The following is a description of a gene set: Reactome Pathway: Synthesis of DNA part of: DNA Replication; S Phase studied in species Mus musculus This event has been computationally inferred from an event that has been demonstrated in another species.<p>The inference is based on the homology mapping from PANTHER. Briefly, reactions for which all involved PhysicalEntities (in input, output and catalyst) have a mapped orthologue/paralogue (for complexes at least 75% of components must have a mapping) are inferred to the other species. electronically inferred by orthology from the curated human pathway, and this is the list of marker genes: Anapc10, Mcm8, Psmb5, Ube2e1, Psmd1, Ube2c, Pola2, Gins1, Psmd13 (NCBI Gene Id 23997), Psma5, Gmnn, Pole, Psma4, Psmb7, Cdc26, Psmb6, Mcm4, Psmc6, Orc1, Psmc1, Cul1, Psma7, Psmc3, Anapc7, Lig1, Pcna, Mcm2, Rpa1, Pold4, Rfc1, Psma3, Ube2s, Anapc2, Cdc23, Psma1, Prim1, Psmd7, Ccne1, Pold2, Pole2, Orc4, Anapc15, Psma2, Ccna1, Psmb4, Gins3, Psmd6, Psmc5, Cdc6, Psmd12, Fzr1, Psma6, Pola1, Orc3, Mcm7, Psmc2, Ubb, Ccne2, Rfc3, Psmc4, Pold1, Orc5, Dna2, Ube2d1, Rps27a